Given this list of marker genes LPGAT1, LCMT2, RNF125, ACOT2 (acyl-CoA thioesterase 2), EFCAB2, LRRC40 (NCBI Gene Id 55631), CIRBP, FLI1, DHRS1 (dehydrogenase/reductase 1, NCBI Gene Id 115817), CCDC181, TOP2B, PLCB2, RAB11FIP4, SLC12A9, ABHD5, IER2, SMIM19, ATRAID, SAP130 (Sin3A associated protein 130), ILK, PCGF1, HBP1, SLC2A9, SERPINB1, ATP6V1G2, EXOSC5, NEK7, TFDP1, MARVELD2, LDLRAP1, PNKP, ASPRV1, CD300LB, SETDB1, BET1L, HGF, EEPD1, ALOX5AP, SMPD1, MYLIP, RGS19, KLF11, NONO, PLEKHF1, FBXO25, RAB30, SMPD5, PNPO, ZNF32, FANCM, MANEAL, MIS18A (NCBI Gene Id 89756), TMEM129, ROR2, GCNT1, SAP30L, FGF2, EMB, PRXL2C, SAXO5, CBLN4, PALM, CREBRF, EPB41, ITFG1, TM6SF1, FOXRED2 (FAD dependent oxidoreductase domain containing 2), USP45, CEP128, CFAP119, AUH, GMFG, CIB1, NXT1, PGAP6, NEMF, CLEC16A, ELAC1, AKIRIN1, TMOD4 (NCBI Gene Id 29765), MAN1C1, HSDL2, ARB2A, SARAF, SVIP, HECTD3, ING1, H2BC3, HIBCH, IFITM2, MGST1, RABIF, HOPX, MTFMT, OLFML2B, OXR1, NTPCR, PURG, ABCA13, MAEA, FBXO16, DNAJC9, SESN3, GLOD4, BAIAP3, CPNE1, BRD3, SLC25A11, COL11A2, ANKRD13D, RSPH3, MRPL34, UCKL1, CCDC62, TMEM18, PDHA1, CD84, CYP27A1, FBXO3, GSK3B, GALNT6, PADI4, SRSF11, FAM43A, NDUFV1, NIPA2, KHDC3L (KH domain containing 3 like, subcortical maternal complex member), ATP13A2, TSPAN5, C1D (NCBI Gene Id 10438), GLIPR1, IRF2BP1, TAF13 (TATA-box binding protein associated factor 13), C8orf82, TUSC2, CHAC1, SHARPIN, CTNNBL1, ZFAT, MANBAL, PTPRK, GPR15, NDOR1, SAMD10, GET4, TESK2, ACD, ZNF740, TMCO3, TGDS, ATG7, C11orf24, LACTBL1, ALDH2, NPR2, SLC23A3, ADD3, PTGER3, AFMID, C5orf34, MRPL10, MFSD10, JCHAIN, DDX59, ZDHHC13, JADE1, PEX10, PCBD2, PAXX, IGFBP6, KDM6A, KREMEN1, SLC35E2B, NAA60, CPNE3, KAT7, CFAP91, HSPB6, MIA2, ARGLU1, GPKOW, YOD1, AHSA1, SMIM7, IFT70B, LSM14A (NCBI Gene Id 91161), MAN2B1, GSC, BBS9, MAP10, LMNTD2, GNPDA2, LINC00511, XPA, H3C7, ERP27, HMX1, CUL4A, LBP, UBR1, here is a description of the gene set: from publication Youn JI, Collazo M, Shalova IN, Biswas SK, Gabrilovich DI (PMID 21954284) Myeloid derived suppressor cells (MDSC) playing the immune suppressive roles in tumor bearing host consists of two major subsets of granulocytic and monocytic cells. Granulocytic MDSC (G-MDSC) express CD11b+ Gr-1high Ly6G+ Ly6Clow and produce high level of reactive oxygen species (ROS). Interestingly, neutrophils are well known ROS producing cells during immune defensive process and share same surface markers with G-MDSC. These similar features always brought the fundamental questions what’s the difference between G-MDSC and neutrophils but it’s not yet proven clearly. In this study, we examined the gene expression of G-MDSC and neutrophils using Affymetrix microarray. Genes up-regulated in comparison of granulocytic myeloid derived suppressor cells (MDSC) versus neutrophils. species: Homo sapiens Human Gene Set: GSE24102_GRANULOCYSTIC_MDSC_VS_NEUTROPHIL_UP